Given this list of marker genes Septin3, Fam107a, Rad51, Pclo, Nefl, Bsn, Nefm, Actg1, here is a description of the gene set: Mouse Gene Set: GOCC_PRESYNAPTIC_CYTOSKELETON species: Mus musculus The portion of the cytoskeleton contained within the presynapse.